Given this list of marker genes MAPK1, GLI3, GLI2, RBM14, ABL1, UCMA, IHH, RUNX2, YES1, MAF, SP7, HDAC4, HEY1, WWTR1, RB1, HEY2, HDAC6, CBFB, BGLAP, AR, SATB2, YAP1, SMAD1, SRC, SMAD4, MAPK3, COL1A1, SMAD6, HES1, ZNF521, HDAC3, here is a description of the gene set: Reactome Pathway: RUNX2 regulates bone development RUNX2 is required for the development of both intramembraneous and endochondral bones through regulation of osteoblast differentiation and chondrocyte maturation, respectively. In its absence, intramembraneous ossification is blocked while endochondral ossification is arrested at the cartilaginous stage. In mice and humans, RUNX2 haploinsufficiency causes Cleidocranial dysplasia, a generalized bone disorder.<br>RUNX2 stimulates transcription of most of the genes constituting the bone extracellular matrix and of BGLAP gene, which encodes Osteocalcin, a bone-derived hormone controlling glucose metabolism, male fertility and cognition.<br>RUNX2 promotes chondrocyte maturation by stimulating transcription of the IHH gene, encoding Indian hedgehog.<br>In response to BMP2 signaling, RUNX2 forms a complex with SMAD1:SMAD4 heterotrimer in the nucleus and stimulates transcription of SMAD6.<br>RBM14, a negative regulator of RUNX2 transcriptional activity, is frequently overexpressed in osteosarcoma. part of: Transcriptional regulation by RUNX2 species: Homo sapiens